Given this list of marker genes Asns, Naalad2, Aspg, Got1, Gadl1, Got2, Aspa, Slc25a13, Folh1 (folate hydrolase 1), here is a description of the gene set: part of: Metabolism of amino acids and derivatives This event has been computationally inferred from an event that has been demonstrated in another species.<p>The inference is based on the homology mapping from PANTHER. Briefly, reactions for which all involved PhysicalEntities (in input, output and catalyst) have a mapped orthologue/paralogue (for complexes at least 75% of components must have a mapping) are inferred to the other species. electronically inferred by orthology from the curated human pathway Reactome Pathway: Aspartate and asparagine metabolism species: Mus musculus